The following is a description of a gene set: Neighborhood of RPA2 replication protein A2, 32kDa in the MORF expression compendium Human Gene Set: MORF_RPA2 Neighborhood of RPA2 studied in species Homo sapiens, and this is the list of marker genes: EIF3I, RPA2 (replication protein A2), MLEC, ORC1, TIMM17A, DIAPH1, CNOT1, SRRM1, POLR2A, TAFAZZIN, MVK, MGAT1, MAP3K11, PFDN1, AATF, AP3B1, NONO, PPIE, PHB2, GTF2F1, CNPPD1, NUP188, ZMYM4, RPRD2, ZBED1, EML3, ESYT1 (NCBI Gene Id 23344), THOP1, ARPC4, SMARCC2, PTPN9, GTF2A2, BUB3 (NCBI Gene Id 9184), FDXR, E2F4, CELA2A, PDE6D, MTX1, ATXN2L, PHB1, M6PR, FANCG, PRKDC, GRK6, PPIF, XPO7, XPO1, PCBP3, KXD1 (NCBI Gene Id 79036), GHITM, ILF2, NDST1, IMMT, CNTN1, CNP, WWOX, ADAM15, COPS6, USP11, MFN2, TEX261, PPP1R10, ALDH4A1, DDX11, EPAS1, TXLNA (NCBI Gene Id 200081), PRPF31, PRKAG1, OTUB1, ENTREP3, LANCL1, MCRS1, B4GALT3 (NCBI Gene Id 8703), KMT2D, CAD, GSK3A, SEPTIN7, NUP62, METAP1, DCAF7, SMARCC1, EIF2S2, XPO6, OGDH, AFG3L2, CNOT4, CASP2, CALM2, TSFM, PSD4, PSMD2, ZNF131, ARIH2, ZC3H15, MCM2, GTF2H3, PLIN3 (perilipin 3), ELK1, SERP1, CCT4, PSMA1, SUMO2, VDAC3, CLSTN1, CS (NCBI Gene Id 94822), CAPZA1, FKBP15 (FKBP prolyl isomerase family member 15), POLA2, CTDNEP1, PRKCSH, PRPF8, AGPAT1, NFRKB, PKMYT1, ABL1, NELFB, EIF3M, DEXI, GPAA1, TCOF1, PARN, ASH2L, RXRB, VARS1, SFSWAP, RPN1, ADSL, IFRD2, DDX49, YWHAQ, DYRK2, PLPBP, USP19, HDAC2, SMNDC1, EIF6, RTCB, DDX18, HNRNPA2B1, VAMP3, CAPRIN1, SMARCD1, DRG1, CDC25C, NUDT3, TMED9, CRYBA4, HMGN4, KHNYN, PMS2P3, HNRNPL, RPS6KA3, BRD8, SNRNP200, COQ9, LRPPRC, PITPNM1, IGSF9B, SREBF2, AP3S1, NUDT1, LDHA, DNAJC8, IKBKG, PARP2, CDK2, WDR18, NAP1L4, SUMO4 (small ubiquitin like modifier 4), DDB1, PGK1, EBP, LSM12, MRPL9, USP5, MEN1, PRPH, KHDRBS1, ARL6IP1 (ADP ribosylation factor like GTPase 6 interacting protein 1), PDXDC2P-NPIPB14P, TCEA1, BMI1, PABPN1, CSNK2A1, KDM3B, CSK, RAD54L, EIF1AX, PWP1 (NCBI Gene Id 11137), PCMT1, HNRNPD, GRB2, ZPR1